Given this list of marker genes Wdr48, Nlrp4f, Tmem167, Tmem128, Slc6a20b, Mrps17 (NCBI Gene Id 66258), G3bp2, Clcn4, Zfp606, Matr3, Irf2bp2, Fhip1b, Dsg1c, Pear1, Lcorl, Tmem232 (NCBI Gene Id 381107), Rab6b, Npr3, Bbof1, Bnipl, Cutc, Sinhcaf, Usp36, Hps3, Ube3a, Phf20l1, Dnal1, here is a description of the gene set: species: Mus musculus from publication Chen Y, Wang X (PMID 31504780) Mouse Gene Set: MIR_6921_3P Genes predicted to be targets of miRBase v22 microRNA mmu_miR_6921_3p in miRDB v6.0 with MirTarget v4 prediction scores > 80 (high confidence targets).